The following is a description of a gene set: Mouse Gene Set: MIR_1249_3P from publication Chen Y, Wang X (PMID 31504780) species: Mus musculus Genes predicted to be targets of miRBase v22 microRNA mmu_miR_1249_3p in miRDB v6.0 with MirTarget v4 prediction scores > 80 (high confidence targets)., and this is the list of marker genes: Skor1, Sdhaf2, Smpd3, Nrarp, Chrna1